Given this list of marker genes Enpp5, Nudt13, Nudt6, Enpp1, Nudt17, Enpp2 (ectonucleotide pyrophosphatase/phosphodiesterase 2), Nudt12, here is a description of the gene set: Mouse Gene Set: GOMF_DINUCLEOTIDE_PHOSPHATASE_ACTIVITY Catalysis of the reaction: a dinucleotide + H2O = 2 mononucleotides. studied in species Mus musculus